Given this list of marker genes UTP6, WDR36, WDR3, PWP2, UTP18, here is a description of the gene set: studied in species Homo sapiens A protein complex that forms a subcomplex of the 90S preribosome and can interact directly with the 5' External Transcribed Spacer (ETS) of the full length pre-rRNA transcript. In S. cerevisiae, it sediments at 25-30 S and is composed of Pwp2p, Dip2p, Utp21p, Utp13p, Utp18p, and Utp6p. Human Gene Set: GOCC_PWP2P_CONTAINING_SUBCOMPLEX_OF_90S_PRERIBOSOME